Given this list of marker genes RSRC2, PTX3, CDC42BPA, RGCC, HBB (NCBI Gene Id 3043), CCL8, TCF7L2, CXCL8 (NCBI Gene Id 3576), INTS6, MAFF, CXCL11, XIST, GBP1, CA1, CCL3, TUBB2A, SOD2, IL1B, HBA1, TPSAB1, H2BC12L, CXCL10, ZBTB10, RHAG, CCL5, CXCL6, GADD45B, NR4A2, HBG1, IL1RN, CXCL13, RRAS2, CLK4, CXCL2, DDIT4, AKR1C1, INHBA, CYP1B1, NFAT5, H1-2, CCL19, APOE, ICAM4, H2AC6, CCL20, PMAIP1, CELA2B, PRKAR2B, SERPINB2, KMT2A, CXCL5, H2BC12, SMC3, JUN, BCL3, FXR1, PTGS2 (NCBI Gene Id 5743), RGS1, APOC1, TRA2B, here is a description of the gene set: Human Gene Set: GRAHAM_CML_QUIESCENT_VS_NORMAL_DIVIDING_UP Genes up-regulated in quescent CD34+ cells isolated from peripheral blood of CML (chronic myeloblastic leukemia) patients compared to the dividing cells from normal donors. Quiescent and dividing hemopoietic stem cells (HSC) display marked differences in their ability to move between the peripheral circulation and the bone marrow. Specifically, long-term engraftment potential predominantly resides in the quiescent HSC subfraction, and G-CSF mobilization results in the preferential accumulation of quiescent HSC in the periphery. In contrast, stem cells from chronic myeloid leukemia (CML) patients display a constitutive presence in the circulation. To understand the molecular basis for this, we have used microarray technology to analyze the transcriptional differences between dividing and quiescent, normal, and CML-derived CD34+ cells. Our data show a remarkable transcriptional similarity between normal and CML dividing cells, suggesting that the effects of BCR-ABL on the CD34+ cell transcriptome are more limited than previously thought. In addition, we show that quiescent CML cells are more similar to their dividing counterparts than quiescent normal cells are to theirs. We also show these transcriptional differences to be reflected in the altered proliferative activity of normal and CML CD34+ cells. Of the most interest is that the major class of genes that is more abundant in the quiescent cells compared with the dividing cells encodes members of the chemokine family. We propose a role for chemokines expressed by quiescent HSC in the orchestration of CD34+ cell mobilization. Disclosure of potential conflicts of interest is found at the end of this article. from publication Graham SM, Vass JK, Holyoake TL, Graham GJ (PMID 17717066) studied in species Homo sapiens